Given this list of marker genes DHX36, RELA, NFKB1, IRF7, NFKB2, MYD88, DHX9, here is a description of the gene set: studied in species Homo sapiens part of: Cytosolic sensors of pathogen-associated DNA  Reactome Pathway: DEx/H-box helicases activate type I IFN and inflammatory cytokines production DHX36 and DHX9 are aspartate-glutamate-any amino acid aspartate/histidine (DExD/H) box helicase (DHX) proteins that localize in the cytosol. The DHX RNA helicases family includes a large number of proteins that are implicated in RNA metabolism. Members of this family, RIG-1 and MDA5, have been shown to sense a non-self RNA leading to type I IFN production. RNA helicases DHX36 and DHX9 were found to trigger host responses to non-self DNA in MyD88-dependent manner. DHX36 sensed CpG class A, while DHX9 sensed CpG class B. Both DHX36 and DHX9 were critical for antiviral immune responses in viral DNA-stimulated human plasmacytoid dendritic cells (pDC) (Kim T et al. 2010).